Given this list of marker genes ABCG2, NLRP1, SYNE3, IL1R2, DOCK2, FAM168B, PYROXD2, C1orf162, CTNND1, LRMDA, GSTT1, RARA, PARVG, ABL2, HACD2, F13A1 (coagulation factor XIII A chain), SLC38A6, IL1RAP, UQCRB, BLZF1, TSPAN32, SLC2A3, BTG2, AGL, UGGT1, ATF5, PLAT, PLS3, SGMS2, AGO2, GAS7, NCOA7, CBX7, GMFG, NEMP1, HOMER1, NCF2, ATP1B1, CELA2A, EIF3K, CATSPER2, CYB5R1, TMEM45B, TNC, MIR101-1, RXRA, ERMP1, ITGAM, PYCARD, BPNT1, RIN3, DTX4, RPL24 (NCBI Gene Id 6152), CXCR1, PTX3, BTK, ESYT1, KRT17, RAB7B, SRSF6, TM6SF1, NDUFAF2, HADHB, NFKBIZ, MKNK1, SCARB1, CLEC10A, USP9X (ubiquitin specific peptidase 9 X-linked), MSRA, ASPHD2, YIF1B, S100A4, UBASH3B, GASK1B, PCYT1A, ERRFI1, ATP8A1, ARHGAP24, MYO1E, GCLC, MBNL1, TLE3, ZC3H12C, TRAF3, CLDN1, PRKD3, PTGS1, ANAPC15, ITGB5, ACE, TLNRD1, NRP1, AHCY (NCBI Gene Id 191), MGMT (NCBI Gene Id 4255), ZC3HAV1, ATP13A3, MGST2, HTT, HADHA, TACC1, TSC1, ALDH6A1, SDF2L1, CYP1B1, AAK1, ATM, COP1, ABAT, PEMT, GALM, GRHL1, HSD17B10, TMEM121B, MIR3142HG, GRAMD2B, ACTN1, GSN, CD93, CLN3, RPL27, FBP1, DNPH1, SPCS3, ABHD2, RPS4Y1, ZNF710, P2RY6, NAGA, PKIB, ICAM3, ABCC4, ASAP1, EVL, PLXDC2, PPARD, LINC00960, PECAM1, TTC3, TIMMDC1, PLEKHO2, ATP11B, QPRT, VPS9D1, DNASE1L1 (NCBI Gene Id 1774), CLEC4G, TMC7, BLVRB, MAP1S, CDC42EP3, NLN, PEAK1, TPMT, PPT1, EPAS1, WWC3, GLIPR1, IL17RA, MAP2K3, ARHGAP26, CMTM3, FXYD5, MEGF9, CYFIP1, ZNF501, TAPT1, EMB (NCBI Gene Id 133418), RNASE6, SLC47A1, NXN, SH3GL1, LMNA, NDUFB6, LAMC1, TARBP1, MAP4K1, PGK2, STX12, SNX29, HUWE1, SKAP2, RPS9, PON2, TRPS1, DNASE1L3 (deoxyribonuclease 1L3), UBA52, TTC39B, EXOSC5, RGS10, BRWD3, JAZF1, PRKX, ARHGDIB, GPD1L (NCBI Gene Id 23171), PLA2G4A (NCBI Gene Id 5321), MS4A6A, ZNF106, here is a description of the gene set: Human Gene Set: GSE14000_4H_VS_16H_LPS_DC_TRANSLATED_RNA_UP Genes up-regulated in comparison of polysome bound (translated) mRNA in dendritic cells (DC) at 4 h after LPS (TLR4 agonist) stimulation versus those at 16 h after the stimulation. species: Homo sapiens Dendritic cells (DCs) are the sentinels of the mammalian immune system and they undergo a complex maturation process mediated by activation upon pathogen detection. Recent studies described the analysis of activated DCs by transcriptional profiling, but translation regulation was never taken in account. Therefore, the nature of the mRNAs being translated at various stages of DC activation was determined with the help of translational profiling, which is the sucrose gradient fractionation of polysomal-bound mRNAs combined to microarrays analysis. Total and polysomal-bound mRNA populations were compared in immature (0h) and LPS-stimulated (4h and 16h) human monocyte-derived DCs with the help of Affymetrix microarrays. Biostatistical analysis indicated that 296 mRNA molecules are translationally regulated during DC-activation. The most abundant biological process among the regulated mRNAs was protein biosynthesis, indicating the existence of a negative feedback loop regulating translation. Interestingly, a cluster of 17 ribosomal proteins were part of the regulated mRNAs, indicating that translation may be fine-tuned by particular components of the translational machinery. Our observations highlight the importance of translation regulation during the immune response, and may favour the identification of novel gene clusters or protein networks relevant for immunity. Our study also provides information on the possible absence of correlation between gene expression and real protein production in DCs. from publication Ceppi M, Clavarino G, Gatti E, Schmidt EK, de Gassart A, Blankenship D, Ogola G, Banchereau J, Chaussabel D, Pierre P (PMID 19943945)